Given this list of marker genes PPM1B, ANO6, RIMS2, RNF180, DSEL, DHX15, YY1, BMPR1A, HOOK3, IFNA8, CYYR1, CASP10, SPATA6, INSM1, ZNF117, MACC1, TMEM167A, NEGR1, GALR1, HNMT (NCBI Gene Id 3176), CFAP418, DYNLT5, VEGFA, FRMD4A, AK7, MAP2, CASK, ZFHX3, DTX3L, HYCC1, KIAA0408, TMBIM4 (NCBI Gene Id 51643), CACNB4, GPC6, FZD3, BTBD3, ENTPD5, NR1D2, COL6A6, ZSCAN25 (zinc finger and SCAN domain containing 25), XIAP, RAP2C, SREK1, CENATAC, MRPS10, CEP41, UBE3A, PDE10A, UTP25, TNIK (TRAF2 and NCK interacting kinase), AHSA2P, KCTD16, STAU2, URI1, MEIOC, ASCC1, EPC2, PDK3, TSPAN31, LUZP2, SLC36A4, PDGFA, PSD3, CLPX, ACTR2, UNC5C, SUZ12, ZFY, NPAS3, SENP6, KAT6A, AZIN1, PTGDR, DZIP1, EPC1, REEP3, PHIP, TMF1, SELL, PSME4, SUCLA2, MIB1, INTS2, GUCY1A2, LARGE1, RBFOX2, PABIR1, TMED7, DENND4A, TENT4B, OAS2, SPRYD7, OR11A1, ARAP2, ATAD1, SLC24A2, ACSL4, ELAPOR2, SCML1, TLCD4, ACSS3, OXSR1 (oxidative stress responsive kinase 1), BCAT1, IFNA2, TMEM168, PTH, LPP, CA8, RIOK3, CEPT1, SSBP2, CANX, SLC17A8, PCDHB6, SPECC1, MBNL2, SPAST, ALDH6A1, SIPA1L3 (NCBI Gene Id 23094), FAM114A2, COL25A1, GPATCH2L, LRRN1, TRAPPC8, EPN2 (epsin 2), SCAF11, ARFGEF1, LPIN1, ATP9A, FSD1L, EIF3A, DCUN1D4, PRTG, DNAJC8, RHBDF2, DCBLD2, MAPKAPK5, TRPV1 (NCBI Gene Id 7442), ITPR2, COPG2, LRRC66, WNK3, ZC3H12B, PCLO, IKZF2, USP25, PEG3, PKHD1L1, UBE2K, SAYSD1, AMD1, ARHGAP5, IRX2, VPS13C, GNG12, LUC7L3, LRP12, PLCG2, SLC1A2, TRMT10A, NOG, FOXA1 (forkhead box A1), KPNA3, COL15A1, DENND5B, PAX5, LRRC41, TERF1, INO80D, MAN1A2, WDR44, ZNF503, SLK, NRP1, NAA16, SHOX (SHOX homeobox), ZNF599, YBX3, SIDT1, RAB6A, MAPK9, PHC3, ZNF608, SNRNP48, CYP39A1, CAPS2, ZNF706, PRKAR2B, MON2, FEZ2, SNTG1, KCNT2, ZWINT, MANEA (mannosidase endo-alpha), WDR20, EPB41L4B, PIN4, DOCK2, ZC3H11A, PAK3, TUT4, GABRA4, SNAPC1, TMEM65, STK17B (serine/threonine kinase 17b), ZNF736, PCMTD1, OPRK1, MATN3, COP1, MAP3K12, SELENOP, AHR, PCSK5, PKN2, ZNF699, CEP170, BCAR3, MTF1, C5orf24, ART3, NCBP2, GOLT1B, RUFY3, RIC8B, CDK6, SCAI, NDEL1, GCLM, S100PBP, ACER3, DEPDC1, SOX11, GSTM3, GJA1, PDE4D, BRINP2, MCFD2, PTGR3, ZNF776, FAM76B, UBE2R2, RPS6KA6, PPM1F, ITGA6, FOXN2, CCDC50, SLC16A9 (solute carrier family 16 member 9), FAM169A, LNX1, PACRGL, MOB1A (MOB kinase activator 1A), SRSF12, ZDHHC15, TPR, MN1, HECTD2, ZFAND3, ABL2, LMO7DN, FXR1, SESN3, SP4, PLS3, MAPK1IP1L, SLC30A7, CAMLG, TOB1, KCNC2, SERP1, MAP4K3 (NCBI Gene Id 8491), CHURC1, ATP6V1C2, JCAD, LINGO2, PHF6, RPS3, PTGER3, C14orf132, DLC1, WWP2, GRIA2, CEP135 (centrosomal protein 135), SYAP1 (synapse associated protein 1), CAVIN2, KDM7A, FERMT1, PPP1CC, HEY1, LCORL, LGALS12, ZXDB, VPS4B, MBTPS2, SEC63, CHD9, FUT8, LRCH2, SBNO1, SORT1, SNX27, SLFN13, ARIH1, TMEM183A, NPHP3, RALGPS2, BRD1, TMPRSS11F, ADAM8, LIN54, BBX, VSX1, VPS13B, DGKH, SLC27A6, MFHAS1, RADX, SCN9A, PLPPR4, AFG1L, HMGN4, TBL1XR1, PTPN4, MIER3, SATB1, SRGAP2C, FKBP7, CREBZF, PUM1, GRIK1, TEAD1, HIPK1, SRPK1, PDE1C, SGMS2, SEC62, PPP3CB, XPOT, MAP4, MICU3, PLSCR4, RGPD5, CHP1, MAP3K2, ZFP3, KCNH1, TSR1, PIK3CA, CCDC112, STEAP2, RBM28, IRF8, PPP4R2, TSC22D2, UGGT1, EIF2D, NR4A2 (nuclear receptor subfamily 4 group A member 2), CHM, SNX2, C18orf54, AFF1, TNRC6B, KLHL31, RAB2A, PIK3CG, COBLL1, MAPK1, KDSR, TARDBP, PYGO1, RPS6KB1, PABPC1, SPRYD3, DUSP7, CPEB3, SH3RF1, ZNRF3, RNF138, DENND1B, EXOC7, ASTN2, SMG1, GCC2, TIPARP, ZNF713, CNTNAP2, CRAMP1, QKI, RAB6D, UBE2N, SP3, DDX46, RYR2, CHIC1, PDS5B, DICER1, SHPRH, MAP4K5, TAF1B, SPTLC1, ZBTB20, DYNC2H1, PDCD4, TGFBR3, GLYATL3, IGSF11, RNF217, PRKAA2, SYNCRIP, MOB1B, SLAIN2, NIT2, RAB11B, KIF21A, LHX2, DMD, KLF7 (KLF transcription factor 7), RUNX1T1, UBR2, CADM2, ANGPT2, FAM120A, GK5, CDK5R1, MCC, ERC2, RTCA, HYOU1, PXDC1, RB1CC1, SLC4A7, CAMSAP2, ATXN7 (ataxin 7), CNTNAP1, TRHDE, HNRNPR, PPM1L, HYCC2, ZBTB39, MCTP1, SPRED1, SMIM15, ATL2, OSBPL8, RNF2, APPBP2, TMEFF2, TIGAR, FNIP1, CREB3L2, C17orf58, SUMO4 (small ubiquitin like modifier 4), ASPH, ARMC3, GBP2, PDIK1L, PROSER2, GLT8D2, NCOA3, TICAM2, API5, ARHGEF38, SALL1, FRMD4B, CGNL1, NSD1, SOCS4, ZMAT3, TDRD15, ZMYM2, USP37, BMP2K, RC3H1, SHE, RPS6KA3, MTMR7, PTAR1, SCN7A, LMO4, CXCL13, RANBP3L, MAP7, FNDC3B (fibronectin type III domain containing 3B), SYCP1, MYT1, KPNA1, ZKSCAN8, STXBP5, TTPAL, DDX4, DSPP (dentin sialophosphoprotein), OTUD4, ZNF644, RIC1, LRRC58, WASL, PCNX1, RGPD8, RC3H2, SIRT1, HOXB2, MOB3B, ESCO2, GNAI1, TMEM71, CYP20A1, MBLAC2, ARMC8, XPR1, AKIRIN1, OTUD6B, CROT, CNTLN, GPCPD1, PKD2, MIER1, G2E3, TULP4, PRPF38B, POFUT2, CALB1, ASPN, PDE3B, CREBRF, NFAT5, PTP4A2, FOXD1, ZNF710, BCOR, PAK2, ANKRD28, NOL4, RLIG1, GPR37, RAB21 (NCBI Gene Id 23011), FAM124B, UBR3, TMTC1, LPAR5, TMEM183BP, ONECUT2, UBQLN2, LIN7A, PPM1A, NECAB1, CTSB, ZFYVE16, GABRG1, CPNE3, BRWD3, PHF21B, PID1, SLC44A5, TAFA2, TMEM245, NEK7, TCFL5, CLCA2, XRN1, DISC1, TRUB1, FBXO33, ATAD2, STK3, RGPD6, HERPUD2, NCSTN, here is a description of the gene set: Genes predicted to be targets of miRBase v22 microRNA hsa-miR-186-5p in miRDB v6.0 with MirTarget v4 prediction scores > 80 (high confidence targets). Human Gene Set: MIR186_5P from publication Chen Y, Wang X (PMID 31504780) species: Homo sapiens